Given this list of marker genes Phf14 (NCBI Gene Id 76289, PHD finger protein 14), Fgd2, Kctd15, Car8, Fblim1, Ctla2a, Adamts5, here is a description of the gene set: species: Mus musculus from publication Cui A, Huang T, Li S, Ma A, Pérez JL, Sander C, Keskin DB, Wu CJ, Fraenkel E, Hacohen N (PMID 38057668) Mouse Gene Set: CUI_MAST_CELL_TGF_BETA_1_RESPONSE_UP Cytokines mediate cell-cell communication in the immune system and represent important therapeutic targets. A myriad of studies have highlighted their central role in immune function, yet we lack a global view of the cellular responses of each immune cell type to each cytokine. To address this gap, the authors created the Immune Dictionary, a compendium of single-cell transcriptomic profiles of more than 17 immune cell types in response to each of 86 cytokines (>1,400 cytokine-cell type combinations) in mouse lymph nodes in vivo. A cytokine-centric view of the dictionary revealed that most cytokines induce highly cell-type-specific responses. For example, the inflammatory cytokine interleukin-1β induces distinct gene programmes in almost every cell type. A cell-type-centric view of the dictionary identified more than 66 cytokine-driven cellular polarization states across immune cell types, including previously uncharacterized states such as an interleukin-18-induced polyfunctional natural killer cell state. Genes positively differentially expressed in cell type: Mast cell upon treatment with cytokine: TGF-β1 in mouse lymph nodes in vivo.